The following is a description of a gene set: studied in species Homo sapiens Human Gene Set: HP_LOSS_OF_SPEECH Loss of speech, and this is the list of marker genes: LSM11, RNASEH2A, CHMP2B, SPG7, CLN8, MAPT, PSAP, ALS2, MAN2B1, GRN (granulin precursor), NAXD, RNASEH2B, RNASEH2C, RNU7-1, GABBR2, ABCD1, NPC1, SAMHD1, ARSA, VCP, BSCL2, PPT1, NPC2, IRF2BPL (interferon regulatory factor 2 binding protein like), ADAR, SLC19A3, SARDH, TPK1, AARS2, GRIN2A, NTNG1, TREX1, SQSTM1, TREM2, ERLIN2, TMEM106B, SMC1A, GALC, HGSNAT, IFIH1, PSEN1, GM2A, ALDH18A1, MECP2, PRNP, CDKL5